Given this list of marker genes Cd81, Smpd3, Abcg1, Ccl2, Ces1c, Ces1b, Ces1a, Akt1, Cd9, Pparg, Trem2, Ces1d, Fcer1g, Casr, Ces1e, Cd68, Tgfb1, Itgb1, Abca1, Adtrp, Adam17, Ticam1, Mexis, Syk, Mir124a-1hg (NCBI Gene Id 268755), Mylip, Ces1h, Hmgcs1, Apoa1, Apoa2, Srebf2, Ldlr, Npc1, Lpl, Myd88, Socs5, Mia3, App (NCBI Gene Id 319425), Apob, Itgb2, Abcg4, Tlr4, Cd36, Cdh13 (NCBI Gene Id 74373), Ces1g, Ces1f, Tlr6, Apoe, here is a description of the gene set: Mouse Gene Set: GOBP_CELLULAR_RESPONSE_TO_LIPOPROTEIN_PARTICLE_STIMULUS studied in species Mus musculus Any process that results in a change in state or activity of a cell (in terms of movement, secretion, enzyme production, gene expression, etc.) as a result of a lipoprotein particle stimulus.